Given this list of marker genes Btk (NCBI Gene Id 215271), Slc18a2, Snx4, Lyn, Adora3, Rab44, Snap23, Nppa, Vamp8, Pla2g3 (NCBI Gene Id 237625), Ywhaz, here is a description of the gene set: Mouse Gene Set: GOBP_HISTAMINE_PRODUCTION_INVOLVED_IN_INFLAMMATORY_RESPONSE The synthesis or release of histamine following a stimulus as part of an inflammatory response, resulting in an increase in its intracellular or extracellular levels. species: Mus musculus